The following is a description of a gene set: Human Gene Set: GOBP_REGULATION_OF_LOCOMOTION Any process that modulates the frequency, rate or extent of locomotion of a cell or organism. species: Homo sapiens, and this is the list of marker genes: MIR181B1, SULF1, PLAA (NCBI Gene Id 9373), MIR126, MIR196A1, ANGPT2, DOCK5, TCAF2, ACVRL1, AGTR2, SEMA3G, MIR3173, TGFB1, TEX101, PARD6B, WNT4, FGF20, PLG, MIR483, PLXND1, ROBO4, MTUS1, STK10, MIR29B1, MIR221, RECK, MIR208A, MARVELD3, YTHDF1, MIR1-1, TJP1, MIR23A, SEMA4G, TLR4, MIR362, PTPRR, NDRG4, SERPINE2, TCAF1, PLAU, NBL1, AGT, NUMB, SDC4, MIR520D, MEF2C, FGF9, MAPK14, BCAS3, ITGAV, SEMA7A, ZMYND8, PTPN23, RHOA, ZNF268, ADAMTS9, KRT5, PRCP, CCL26, MCU, IGFBP5, CD69, SSH1 (slingshot protein phosphatase 1), MIR151A (NCBI Gene Id 442893), SOX14, DCN, FLNA, MIR640, ACVR1, LEF1, ROCK1, HIF1A, MIR15A, AMOTL2, PTPRU, TBXA2R, CATSPER1, ST3GAL4, EPPK1, MAPK3, CDK6, RIPOR2, VCL, CASR, MIR137, FAT1, COL1A1, PADI2, HTN1, RAC2, MALAT1 (metastasis associated lung adenocarcinoma transcript 1), ANXA3 (NCBI Gene Id 306), RFFL, SPN, INS, DOCK7 (NCBI Gene Id 85440), ADGRG3, MADCAM1, TPBG, MAP2K1, MDM2, TMEFF2, RHOB, MGAT3, OXSR1, IL6R, FBN2, ARF6, SEMG1, RACK1, GPLD1, CCL15, ABL1, CCBE1, TET1, SIN3A, CXCL10, TNFSF14, FERMT1, C5AR1, CARD10, PECAM1, NF2 (NF2, moesin-ezrin-radixin like (MERLIN) tumor suppressor), GNRH1, PFN2, SUCNR1, MIR296, PDGFB, MIRLET7G, SEMA3E, PEAK1, ITGA3, AKT3, CORT, TREM2, DSCAM, UNC5C, PINK1, CLDN4, CLASP2, C5AR2, NOS3, GNAI2, SRC, APPL1, BCL6, ANGPTL3, BRMS1L, DEFB1, UNC5D, ARSB, EFNA1, PPARG, MED23, ADAM10, FGF1, TEK, IL6, CNN2, EPB41L5, SEMA4C, TRIB1, STC1, RIN3, MIR129-1, KIT, VEGFD, PLXNA2, ATP1B2, SYNJ2BP, MIR499A, CXCL12, CCL28, MYCBP2, TPM1, EMILIN2, STMN1, ARHGEF7, STK39, C3AR1, CHST4, MIR135B, CEMIP, LMNA, GREM1, ABL2, HDAC9, DPP4, ITGAX, LAMA4, DAPK3, PTPRJ, DUSP3, NOTCH1, MAP2K2, ABCC8, MIR150, MIR199A1, JAK2, RNASE10, NTF3, AKAP12, PTP4A1, SLAMF8, MEGF8, CORO1A, ADGRB1, ETS1, VPS35, DOCK1, WNK1, MDK, SH3RF2, SYNPO2, PKN1, S100A14, MGAT5, CRKL, SGK1, ATOH7, PLXNB2, VIL1, CTNNA2, NKD1, CD74, AKT2, NRP2, PTPRC, SPARC, DUSP1, XCL2, RIGI, MIRLET7F1, IGF1, MIR34A (microRNA 34a), CITED2 (Cbp/p300 interacting transactivator with Glu/Asp rich carboxy-terminal domain 2), PFN1, S100A11, IL1B, TACR3, RDX (radixin), MIR1908, ING2, FLT1, SOD2, JUP, SLC8B1, MIR379, RNF41, FUT1 (NCBI Gene Id 2523), FBXO5 (NCBI Gene Id 26271), APP, NFE2L2, PLXNA3, GLI1, IL34, APOH, MMRN1, CHST2, MIR588, CCR2, JAM2, CLDN5, TMSB15A, STK24, SVBP, MIR19B1, SELENOK, PTPN2, F10, FGF22, BRAF, EMILIN1, KIF2A, MIR19A, BST1, PIN1, IGSF8, SERPINE1, FIGNL2, SRGAP3, WNT5B, LDB2, CAMK2A, ADRA2A, MAPRE2, INSL3, TAC1, MIR200A, CCL8, PAK1, ANGPT1, ZNF609, CARMIL1, EPHA1, TBX5, KRIT1, SLURP1, TIRAP, AMOTL1, CORO1C, MIR335, CDH5, NKX2-1, CDKN1B, CIB1 (NCBI Gene Id 10519), IL1R1 (NCBI Gene Id 3554), TMIGD3, PTK2B, MIR29C, CCL3L3, SPRY2, RHOD, SRGAP2C (NCBI Gene Id 653464), GSK3B, CHRM4, GHSR, PIK3R1, MIEN1, APOD, SLIT1, MIR130A, PPM1F, TNFRSF18, MMP28, NGFR, FUT4, FRMD5, MYD88, NRG3, CLDN19, RUFY3, VTN, STX4, ARHGAP4, SINHCAF, GDF15, HSPB1, ARID2, USP14, USP17L2, TRIM32, EDN3, BMP7, MAP2K5, PTPRG, GSTP1, MIR361, APELA, VEGFC, FES, APPL2, MIR638, CFAP45, MIR205, APOE, MEOX2, CCL1, ARHGEF39, MET, SEMA6B, SMIM22 (NCBI Gene Id 440335), MIR519D, MIR4500, FSHB, KRT16, ADAM7, FGF8, GAS2L2, PIK3R3, CCL21, CBLL1, MIR92A1, MECP2, SPAG9, PLXNC1, MIR143, POU4F2, ASCL2, RHOJ, PGF, FZD4, SRF, HDAC1, MIR302C, ROBO3, MIR590, CTNNA1, IL12A, FERMT3, CLN3, MIR185 (microRNA 185), RAC3, LAMC2, P2RY12, NCKAP1L (NCBI Gene Id 3071), SEMG2 (NCBI Gene Id 6407), ADARB1, MCTP1, ARHGAP5, AP1AR, DPEP1, FERMT2, DNM1L, HYAL2, ABHD2, MITF, CD9, CCAR1 (cell division cycle and apoptosis regulator 1), MIR551A, LDLRAD4 (low density lipoprotein receptor class A domain containing 4), MIR193A, SMOC2, SPI1, CARMIL2, MIR214, CCL4L2, RCC2, WAS, KIF26A, CFAP20, MIR101-1, UBE2I, ROCK2, RABGEF1, F7, MIRLET7B, FLT4, TNXB, CLDN3 (NCBI Gene Id 1365), GPNMB, XG, GHRL, DDR2, SUN2 (NCBI Gene Id 25777), MIR222, MIR93, CXCL8, FOXO4, GPR18, GADD45A, NIPBL, PLCG1, SRCIN1, JAG1, MIR711, PLXNB1, LMO4, CGA, PLXNA1, NINJ1, MIR15B, DAPK2, NUS1, NCK1, HOXA7, CCDC25, SPRED1, MIR892B, ANGPT4, MAGI2, TMIGD1, SLK, CXCL16, SEMA4F, HMOX1, CCN4, ADIPOR1, IQSEC1 (NCBI Gene Id 9922), ACTN4, ARHGAP18, MIR338, ATP5F1A, RAP2A, RBBP7, RIN2, PDGFA, ADORA1, SAP30L, CCL2, BEX4, SP1, CCN1, GNA12, PRDM14, VASH1, MCC, PDPK1, CDK5, EVL, MIR492, C1QTNF8 (C1q and TNF related 8), GPSM3, TNFRSF14 (NCBI Gene Id 93208), FUT3, PDCD6, PLA2G7, MSTN, HMGB1, TTBK2, DUOXA2, CLIC4, SAP30, NOG, CTSH, GNB3, DAAM2, TACR1, SCAI, PIP5KL1, ELANE, MIR182, MTA2, NAV3, MIA3, VSIR, CCL7, MIF, TMSB4Y, ELP3, DEFB131A, RHOC, AJUBA, MIR410, FAM89B, DDRGK1, MIR21, MMP2, MMP7, FOXF1, ONECUT1, S1PR1, MIR449A, KIF9, HDAC7, MAPK1, PODXL, FGF7, P2RX4, SEMA5A (semaphorin 5A), SORL1, ARHGDIB, IL16, HRAS, C8orf44-SGK3, NTRK3, DNAJA4, MIR223, KIF21A, MYSM1, TBC1D24, FEZF2, CDC42, SCG2, PLVAP, MIR543, ACKR3, CCL11, CYP19A1, DAG1, TAC3, STK26, LGMN, CD200R1, CX3CR1, JUN, CEACAM1, KDR, SEMA4B, PAX6, ACVR1C, NTN1, CXCR4, SERPINB3, MIR10A, NRP1, BMPER, SCARB1, PTGER4 (prostaglandin E receptor 4), SPATA13, CD99, NF1, TWIST1, BAG4, MIR16-1, TMSB15C, LYVE1, SMAD3, CCR7, MIR665, CEACAM6, PDCD10, ZEB2, RARRES2, MIR181D, RIPK3, HAS1, ATP2B4, SEMA3C, DRD1, JCAD, LAMA5, MIR939, F2RL1, RRAS2, TNF, GLUL, CXCL17, CCL5, BMP10, ENG, FGF10, ADAM17, OGT, CFAP69, MICOS10-NBL1, PHLDA2, MMP3, ITGB1BP1, BCR, ZC3H12A, ACTG1, ECM1, TBR1, ADA, EPB41L4B, CTTN, IFITM1, LRRC15, CCL22, PTPRT, GRIA1, PTPN1, ARHGEF2, CASP8, CCL24, MOSPD2, TIMP1, MIR329-1, CCL19 (C-C motif chemokine ligand 19, NCBI Gene Id 6363), MIR493 (microRNA 493), ARID4B, GRB7 (growth factor receptor bound protein 7), PLET1, PDGFC, ROBO1, BCAR1 (NCBI Gene Id 9564), WASHC1, SPNS2, GTPBP4, AKIRIN1, PODN, RICTOR, LRIG2, GPER1, CD300A, NR2E1, MAP4K4, CD40, TNFAIP6, ADTRP, TNFSF18, ENPP2, STAT5A, SLIT2, FGF3, C5, SEMA3D, MCAM, BMERB1, HGF, EPHA4, FADD, FGF18, CCL25, FGR, MIR146A (NCBI Gene Id 406938), MMP9, TERT, CD81, EMP2 (epithelial membrane protein 2), SOX9, MIR132, MIR210 (NCBI Gene Id 406992), ITGA5, AIRE, IGFBP3, FGF17, CADM4, IRS2, ROR2, RTN4 (reticulon 4), ADGRG1, SPOCK2, SEMA5B, PTN, ADAMTS1, MIR9-1, RAB25, FGF16, ITGB1, PTGS2, PDGFRA, PLCG2, PRKCA, THBS4, MIR24-1, BRMS1, RBBP4, WDPCP, MYO1C, PLXNA4, BSG, IL27RA, MIR181A2, CCDC125, ALOX15B, ANO6, ADGRA2, CAMSAP3, GPR183, PITX2, FGF21, TRIP6, YTHDF3, DOCK4, LAMA2, GATA3, CAV1, C1QBP, MIR320A, TNN, FGF5, ATOH8, LRP1, RRAS, MIR10B, XBP1, GDF2, SDCBP, CYP1B1, CCN3, MEAK7, FGF19, RNF7, HDAC2, MIR31, TRADD, LAMA3, CXCL13, GPI (glucose-6-phosphate isomerase), IGSF10, KANK1, GRN, MACF1 (microtubule actin crosslinking factor 1), SLC26A5 (solute carrier family 26 member 5), FGF2, PTPRO, CD151, MAPK15, IL23A, CXCR3, SNCA, PTPRM, FGF23, MIR128-1, SSX2IP, SGK3, MIR1290, TTLL6, MAZ, STAT3, FBXO7, MACIR, MIR20A, MIR497, PDPN, CCL20, POSTN, SIN3B, LAMA1, BMP4, PDGFD, ZNF580, IL33, EDN2, MIR212, BCL2, RIPOR1, CCL14, FOXP1, ROBO2, SYNE2, CLXN (NCBI Gene Id 79645), ARTN, PRKCE, THBS1, MIR138-1, BBS4, KIF14 (NCBI Gene Id 9928), GAS6, RET, KLF4, CAPN7, AMOT, CDH13, PATZ1, MIR200C, ARID4A, SIRT1, NODAL, RAB11A (RAB11A, member RAS oncogene family), SYDE1, PTEN, BMPR1A, FGFBP1, MMP14, NR4A3, FLRT2, RAPGEF2, ADAM15, CLEC7A, PLK2, TMSB10, EZH2, IDH2, ARRDC3, SPOCK3, CLASP1, CCL18, LDB1, WDR62, GCNT1, IL4, WNT5A, MIR495, GSX2, WNT3A, PTPRK (NCBI Gene Id 5796), NR2F2, PIK3C2A, MIR204, MIR206, SEMA6C, KLRK1, PGAM4, ZP3, SMURF2 (SMAD specific E3 ubiquitin protein ligase 2), MMRN2, GATA2, MIR133A1, DDT, KITLG, DLL4, NEXMIF, SERPINB1, CORO1B, STARD13, THY1, CD47, SFRP1, ADORA3, HRG, TWIST2, ING1, PLEKHG3, MIR503, CCL13, ACVR1B, SEMA4A, DLC1, COL3A1, VEGFA (vascular endothelial growth factor A), MTOR, BBS2, SST, MKKS, TPPP2, CALR, DUSP10, AGO2, TAC4, MIR27A, GCSAML (NCBI Gene Id 148823), ITGA2, IGF1R, LBP, F3, GLIPR2, DAB2IP, SNAI1, MIR224, IL24, RELN, PEAK3, CFL1, MIR487B, SPHK1, MIR30A, ULK4, FGF6, ACE, FOXC2, IQCF1, SMO, NISCH, SEMA6A, F2R, DPYSL3, MYCNOS, PERP, GCSAM, STX3, MIR200B, SRGAP1, SELP, KLRC4-KLRK1, WASL, INSM1, AAMP, MIR1298, HAS2, NHERF1, ATP8A1, FAM83H, SWAP70, MIR22, MYLK, TRPV4, MIR376C, BST2, CSF2, AFDN, DEFB124, NKX6-1, LRCH1, EFNB2, DUOX2, SH3BP1, EPHA2, SCRT2, RGCC, TALAM1, PLPP3, DOCK10, DUSP22, RNF20, P4HB, PTK2, ONECUT2, FGFR1, CYGB, MIR342, APC, GPR15LG, MIR149, PDGFRB, TGFBR1, BVES, RREB1, CASS4, SAP130, SEMA3A, EPPIN, CDH1, PLXNB3, DACH1, MIR448, EPHB2, RAC1, S100A7, CHRD, FN1 (fibronectin 1), STAP1, HSPA8, SOCS7, GAB1, LPAR1, LAMB1, SPINT2, PPARD, TP53INP1, CAMK1D, IRGC, ANXA1, VRK1, IFNG, ELP5, MSN, HTR1D (NCBI Gene Id 3352, 5-hydroxytryptamine receptor 1D), LCN2, TACR2, WNT7A, MYOC, PRR5L, TMEM201, MYADM, NEDD9, MIR491 (NCBI Gene Id 574444), SRGAP2B, NEXN, PYCARD, ITGB3, BDKRB1 (bradykinin receptor B1), RYK, DOCK8, CPNE3, CRIPTO, DRD2, RAP2B, EGF, NOVA2, GPR173, MIR424, LGALS9, ELP6, CFAP206, TMEM102, NSMF, LGR6, SEMA4D, MIRLET7A1, TMSB15B, SELE, FOXO3, MIR152, CD200, TNC, NTNG2, SCRT1, TMEM196, PHLDB2, CCR6, SASH1, ABI3, AQP1, GJA1, SERPINF1, DAB2, CX3CL1, ITGA6, FBLN1, PHPT1, CCL3, FUZ, OSBPL8 (oxysterol binding protein like 8), LGALS3, PIK3CG, INPP5F, LIMCH1, CDH11, CSF1, EDN1, ZNF703, MIR29A (NCBI Gene Id 407021), XCL1, SUDS3 (SDS3 homolog, SIN3A corepressor complex component), DNAI3, ADAM8, MIR27B, PREX1, FGF4, SEMA6D, ERBB4, ACTA2, TNR, MIR26A1 (NCBI Gene Id 407015), EMC10, ADAM9, LRRK2, CSF1R, HSPA5 (heat shock protein family A (Hsp70) member 5), HDAC5, FAM110C, CCL4, TBCCD1 (NCBI Gene Id 55171), SP100, TACSTD2, ARPIN, LYN, ITGA2B, HDAC6, CSNK2B, TGFBR2, PLCB1, TIE1, FUT7, MIR140, GFUS, MAP2K3, DSG3, CAMK2B, NTNG1, PIK3CB, CD99L2, AZU1, TMSB4X, CCL16, CRK, ICAM1, MIR505, CHRM1, DUOX1, VEGFB, SMAD7, ABHD6, MAP3K7, SRPX2, MIR2355, PROX1, CLDN1, PPP2R3A, SNAI2, CEP43, SMPD3, CCR1, HACE1, BMP2, MIR885 (NCBI Gene Id 100126334), PRAG1, DLG5, CUL5, AGER, MPP1, PRKX, FAM107A, PKN2, FPR2, CERS2, SFRP2, MIR218-1, AKT1, CD63, PHACTR1, PRKG1, CAVIN1, SEMA3B, ZNF304, WNT3, SHTN1, ATM, CYRIB, ITGA4, GNA13, SLAMF1, MIR92B, TGFB2, MIR30C2, FUT9, CCL23 (NCBI Gene Id 6368), FER, PPP3CA, SEMA3F, MIR494, BBS1, HBEGF, AIF1, SRGAP2, CMKLR1, MIR451A, MIR145, GCNT2, SHH, TUBB2B, MIIP, PRKD2, TGFBR3, MIR133B, PIK3CD, KIF20B, TIAM1, INSR, MYOCD, PRKD1, DMTN, BMP5, BMPR2, CREB3, ATP5F1B, MINK1, STK4, ADIPOQ, JAM3, RAP2C, EGFR